The following is a description of a gene set: from publication Chen Y, Wang X (PMID 31504780) Genes predicted to be targets of miRBase v22 microRNA hsa-miR-371b-5p in miRDB v6.0 with MirTarget v4 prediction scores > 80 (high confidence targets). studied in species Homo sapiens Human Gene Set: MIR371B_5P, and this is the list of marker genes: LSM8, CCNJ, SPAG9, RETREG3, RASGRP4, ZNF765, POLR2M, TTN, ST6GAL2, SART3, FGD2, PIGW, PLEKHF2, SPACA9, ZNF845, MEFV, GSTCD, TOP3A, GM2A, CCDC50, FBXL20 (F-box and leucine rich repeat protein 20), KIAA1143, ZNF568, NUGGC, SPN, ZNF736, RARS2, HAUS5, NCBP3, TRPM6, KLHL30, CISD2, TEDDM1, FEZ1, SCN9A, VPS33B, ASPN, GUCY1A2, ORAI3, ERCC6L2, ATXN7 (ataxin 7), OCLN, CCNT2, ZNF286B, ARF4, PSTPIP2, TIMM10B, LINC02897, UCK2, GSDMA, DHRSX, SUMF2, ZNF785, COLEC10, TOGARAM1, RBBP4, SH3D19, ARMCX3, TMEM52B, AFG2A, VIP, THUMPD2, MRPS30, GOSR2, GNG4, ZNF793, H6PD, MYO5C, TXNIP, POLH, ZNF587B, LRP2BP, TRPV1 (NCBI Gene Id 7442), CIPC, ZNF28, ATP1B4, CPS1, KBTBD6 (NCBI Gene Id 89890), VPS26A, WHAMM, TGFBR1, TENT4B, KALRN, PTER, FOXL2NB, CHSY1, MPHOSPH9, BLOC1S2, MAP4, ZCCHC4, MYO3B, ALDH16A1, MRPS11 (NCBI Gene Id 64963), ZFP14, ZSWIM4, GRSF1, MRPL19, MRFAP1, PLAC8, MSMO1, ZNF426, SCML2, CNTLN, MARVELD2, FZD2, CDC5L, ZC3H6, MOB3B, POLR2J3, WDR5B, ATXN3, ZNF600, ZNF850 (NCBI Gene Id 651192), PRR23A, SCD5, RAD51AP2, BAG5, CNOT6L, KLF5, TGS1, SLC4A8, ZNF124, EMC1, TANGO2, ARHGAP5, SLC17A3, SIGLEC14, OLFML2A, KRT222, LRPPRC, CLDN12, UTP20, MBD4, PABPC5, RP2, SIX4, ELF5, WDR27, OLR1, TASOR, VIPR2, KIF5C, SCARF1, VPS53, SMUG1, ENAH, FRG2, ZNF451, TMEM170B, MTHFD2L, GPR37L1, PCDHB9, SLC15A5, MGA, ZBTB7A, CYP8B1, PIP4K2A (NCBI Gene Id 5305), FGF12, TBCB, FSBP, FKBP11, MOCS3, CD3G, MYLK4, HYKK, TPM3, SLC16A4, SKP2 (NCBI Gene Id 86997), C21orf91, HIF3A, UBE2W, USF3, WAC, GABRP, MSS51, EPG5, CEBPB, TXNL4B, VHL, PPP4C, ZNF253, ISL1, CDH6, TPMT, SDHA, SOAT1, SPC24, ST8SIA4, CBL, ARFIP1, SKA1, TIMM23B, HUS1, ELAPOR1, ARSB, TSNAX, RC3H1, PWWP3B, ZNF490, RHPN2, GTPBP3, RASGEF1A, RTCA, ZNF713, SERTAD2, TVP23C (trans-golgi network vesicle protein 23 homolog C), MCTS1, C19orf12, NDRG3, PEAK3, LONRF2, RIMKLB, RAD54L2, INSYN1, GOLM2, MPC2, SALL4, IKZF1, CHMP1B, SMAD4, AFMID, FZD3, ALS2, ATAD5, OLFML1, SULT1E1, ZNF816, CHSY3 (chondroitin sulfate synthase 3), GTF3C4, CLSPN, ZNF22, RLF, KLLN, WDR44, ALG1, FBXO44, C2orf49, SMU1, ZCCHC8, CHP1, PI4K2B, TRDN, SYT15, SLAIN1, C15orf40, TRAF3IP2, GRM3, RSKR, RTKN2, XPNPEP3, CHD6, ADIPOQ, ZNF326 (NCBI Gene Id 64842), IPMK, LRRC51, PSPH, ACTN4, TMEM184C, MAP7D3, SNAPC3, TFCP2L1, FBXO28, PARD6B, ZCCHC24, VSIG10, EMP2, CASTOR2, CSGALNACT2, TXNRD2, TMEM120B, SH3BGRL2, CRIPT, SS18, SNX1, TLCD4 (TLC domain containing 4), HPSE, SLC25A34, RMDN1, ALKBH5, HTR1D, SERPINB13, NHLRC2, IFI6, STIL (STIL centriolar assembly protein), CNBD2, PNPO, BRD2, ADAMTS4, EEF1A1, DOCK1, SDE2, PLEKHA5 (pleckstrin homology domain containing A5), FRZB, FAM20B, CALCB, GAPVD1, FOXK1, KCNJ14, ZNF578, NDUFC2-KCTD14, DUSP3, TNFSF9, TCTN2, COX6B2 (NCBI Gene Id 125965), RNF8, STON1, UBA5, PDZD8, STON2, PHLDA1, TENM3, MS4A10, SLC6A11, MBOAT1, ZMYM6, TRIM16, DISC1, FNBP4, ZC3HAV1, SHCBP1, LY75, GATD1, CFL2, AKR1D1, RBL1, CDCA7L, OPRK1, SENP5, SAR1B, C2orf69, EPB41, TAF8, LETM1, STX11, ZNF681, PAIP2B (NCBI Gene Id 57218), IFNAR2, NPAP1, SLC35F6, SLC25A32, ALDH6A1, COX15, PPM1A, NUFIP2, SLU7, FUS (NCBI Gene Id 406232), RBM8A (RNA binding motif protein 8A), RRM2, PTEN, SUPT7L, DTX3L, PIK3CD, CACNA1D, FGF14, TFAP2C, FAM204A, ZBTB2, FABP7, ZNF816-ZNF321P, SLC24A1, ARL6IP1, MTRR, NEXMIF, DCP2, TMF1, RNF125, CAMLG, ELAVL2, GPANK1, S1PR2, PGR, GTF2IRD2, NLK, GPATCH2L, AIFM2, TRAPPC2, ATF1, TMEM167B, ZDBF2, SGPL1, UBE2K, MPIG6B, PAICS, HDAC2 (NCBI Gene Id 3066), ATP13A4, DCUN1D5, REEP3, STMP1, HELLS, SOX4, DNAJC14, CDX1, GABPA, ZBTB8OS, MTX3, MAST3, DCDC1, SERF1A (NCBI Gene Id 8293), PSMD12, OSMR, CEP97, SCAF11, LRRC47, PITPNM2, BBIP1, WDR76, PIK3CA, AAK1, KCTD14, GSPT2, ZNF286A, PDE12, ARID5B, SLC13A1, CLEC7A, NOL9, MDM1, ZNF260, DBR1, IYD, BPNT2, ZCCHC14, CR1 (NCBI Gene Id 1378), UHMK1, SEC63, DAND5, G6PC1, STAT2, SFR1, LURAP1, MRPS16, LPP, NDUFC2, ARL17A, C5AR1, LATS1, GINS1, TMEM33, ZNF100, KRR1 (KRR1 small subunit processome component homolog), GNS, ME2, CCSER2, CILK1, SAMD4A, DENND1B, GLB1L3, ZNF557, SHOC2, PTCHD4, AP4S1, TENM4, SVBP, GTF2IRD2B, ACOX1, BLNK, SERPINB9, MFSD8, RIT2, ACACB, PYGO1, MOB1A, KPNA4, METTL6, LRRC19, FLRT2, ZNF527, TSPYL1, ZNF264, ZNF543, SDC2, KRIT1, SVOP, ZNF839, ACTR10, HP1BP3, GEMIN5, GCSAML, PPM1D, ARAP2, DCUN1D1, APOBEC3F, GCOM1, GALNT12, GPI, TRMT9B (NCBI Gene Id 57604, tRNA methyltransferase 9B (putative)), THAP5, PPP1R15B, GNB4, HEG1, CRCP, UPK3BL1, PHACTR4, PRTG, MPV17L (NCBI Gene Id 255027), APOBEC3D, INPP5B, MCM4, LEPROTL1, SCIMP, TRIM13 (tripartite motif containing 13), ACTR2, CREB1, ARHGAP35, UQCC3, ZNF454, RBSN, NOCT, TMEM239, ZNF530, RAB33B, TMED4, SPECC1, UMPS, RNF207, HRH4, LILRA5, ATL3, TRAF3IP1, SNX22, TWF1, DHH, MATR3, SERBP1, FCAR, IBA57, ZNRF3, CYP1A2, TMED5, CGNL1, CYB5R3, PATJ, NDUFV3, APRG1, SLC12A8, MAVS, TM4SF20, SLC25A45, SERF1B, ZC3HAV1L, IRGQ, PLEKHH2, THOC3, DCAF17, ZC3H12B, APPL1, MRO, SYNJ2BP, EEF1AKMT3, METTL8, INHBE, FAM114A1, NR5A2, COMMD8, PAFAH1B1, CBX5, ZNF552, FGD5, KRBOX4, HECA, HOOK3, RGS9BP, DCUN1D2, PPM1K, BCL10, F3, TOR1B, AUNIP, PIGR, ZNF595, TBC1D7, SLC5A5, GPN3, ARCN1, MAPK1IP1L, KIAA1210 (NCBI Gene Id 57481), PDE6B, UBE2V2, HECW2, CBX6, NCAPG2, CLCC1, JAK2, UTP25, SV2B (synaptic vesicle glycoprotein 2B), MFSD4A, SLC8A1, SGCD, SPATS2L, PCDH10 (NCBI Gene Id 57575), GLG1, PIWIL1, VPS13C, SPIB, GPR83, ZFC3H1, ZBTB25, TAS2R14, OSBPL10, PCDHB16, PAPOLG, FRMD8, DSCAML1, SLC35E2A, TAPBP (TAP binding protein), USP33, PPAT, OR2H1, SKA2, SCD, FAM217B, SATB2, ACKR2, CEACAM8, ZSCAN2, SLC15A1, FXN, ANO6, CCNY, CCL16, CPSF2, TRIM5, NCCRP1, FAM234B (NCBI Gene Id 57613), EIF2S3, TAS2R20, XIAP, DIAPH2, STEAP4, ZNF486, TOR1AIP2, SGCB, IGF2BP3, PDK3, P2RY1, RPL34, DACT2, OGFRL1, OR51E2 (NCBI Gene Id 81285), SPRYD4, VMP1, SINHCAF, ITGAX, PDHA1, ZSWIM1, ARGFX, HACD2, MLEC, TMEM59, PDP2, RPS27L, ICE2, CSK, GCM1, NUDT19, SMIM17, SPAST, FDFT1, AMER2, SIGLEC11, PAPLN, TRA2B, C2orf68, SNTB2, CYLD, PCBD2, EFR3B, UNC80, CASP2, WDR55, CRIPTO (cripto, EGF-CFC family member), HMGN2, CCDC141, ZNHIT6, APOOL, ANKRD17, LAMP2, ZNF587, CYP2B6, NIM1K, LSM11, SNIP1, SLC19A4P, EPB41L4A, TENM2, C16orf54, TERF2, ALDH18A1, CHRDL1, TXNDC9, MDM2, MAPK8, RAD52 (NCBI Gene Id 5893), CFAP210, ZNF281, E2F2, HS3ST3B1, CREBZF, ATP6V0A2, IKZF3, FBXW2, MED17 (mediator complex subunit 17), LPGAT1, ZNF7, PNISR, SSX2IP, FANCF, LYRM7, RAB21, RASSF5, WDR87, KIF3A, SLC2A4, STAM, STRADB, ZNF221, GNA13, TCF7, UBA52, BRIP1, ALG9, PDE7A, AEBP2, MTFMT, MRI1 (NCBI Gene Id 84245), FYB2, CCDC65, RAP1A, GRB14, CEP70, CREB5, ILDR2, CNOT6, FAM111A, RTBDN, NMNAT1, RPP30, ANGPT4, ZNF814, FAM117B, S1PR5, DUSP19, ATF7IP, CYP4F3, PLA1A (phospholipase A1 member A, NCBI Gene Id 51365), KIN, ZNF621, MFAP3L, ATRX (ATRX chromatin remodeler), CD274, TIPRL, SULT1C4 (NCBI Gene Id 27233), SLC16A7, PLAAT5, CEP15, KHDRBS2, ITGB8, SH3TC2, FNDC3A, PTGIS, LIX1L, TMEM106B, ABHD18, HIGD1A, TMEM41B, STX2, RPL15, COX18, EIF4E, MORN4, EDEM1, TKT, ELK4, PTGES3L, VENTX, ZNF808 (zinc finger protein 808), PRR27, VCPIP1 (valosin containing protein interacting protein 1), FSIP1, EXOC5, NIBAN1, CA5B, SCN3B, ZNF780B, KPNA3, MACO1, FAM228B, ZNF626, TRIM59, GNL3L, HPS3, SYNPO2, KLF8, TVP23A, ABCA5, FGFBP3, CEP72, WNK3, TULP4, POU2F3, POLR2J2, EEA1, IRF9, ARPIN, NLRC3 (NLR family CARD domain containing 3), MLANA, ADPRH, CNBP, FAM210A, SLC24A4, ZMYM1, RBMS3, CSDE1, PURB, TRIAP1, TAB3, ACYP2, FRG2C, CEBPZOS, LRRC28, KL, CACNG4, GSR, TRPM7, SURF4, AADAT, FBXL17, MFSD14B, MDM4, SIKE1 (NCBI Gene Id 80143), MCCC2, CSTF2T, FDXACB1, SLA2, SUSD5, PCDHB11, HAVCR2, GKN2, FTO, DICER1, SMC1A, POLR1G, SLC36A2, ZNF709, ZNF493, PHF20L1, R3HDM2, LRPAP1, HMBOX1, CPA4, TSPAN2, CD226, RBM43, AIG1, TNS4, INMT, ZFP36L2, SNX13, TBK1, RLIM, TNFRSF10B, NEK2, PPFIBP1, AP1G1, NAIF1, NOM1, CCDC122, WDFY1, EPHA3, RNF115, ZNF611, QPCTL, GOLGA3, ZNF770, RHD, ZBTB20, MGAT4A, NEPRO, SCAI, NDUFA4, RCN2, TFDP2, UTP11 (UTP11 small subunit processome component), SYT4, NSL1, JAK3, KIF16B (NCBI Gene Id 79757), APOL2, RRP15, CRTAP, KIF18B, STEEP1, SLC9A7, SLC41A2, CAND1, SHOX, LMTK2, TLCD2, SERPINB8, ZC3H13, DNAL1, SLC48A1, DBT (NCBI Gene Id 1629), TOPORS, CYP20A1, ANKS4B, TMX1, C3orf70, COLCA1, CA8, REPS2, SLC30A5, KMT5B, ETFBKMT, APOL6, RPS24, STRIP2, PHTF2, SLC34A2 (solute carrier family 34 member 2), RYR2, GXYLT1, GNG2, MTR, SCAMP1, TMTC1, ZSCAN9, PURA, HOGA1, KLHDC1, RAB11A, AS3MT, LZIC, ZNF805, SLC10A7, ENPP1, MTPAP, RAD54B, CENPA (centromere protein A), PRKCI, NPIPB13, SERPINB1, INTS6, TRIM16L, BVES, MS4A2, ZBTB3, ELOVL5, KDM1A, BAZ1A, TIMM50, ADAMTS18 (ADAM metallopeptidase with thrombospondin type 1 motif 18), MYLK3, NF2, FOXP2, ZNF699, PRELID2, ZNF101, RHNO1, CYP51A1